Given this list of marker genes SOX7, MADCAM1, CYYR1, LINC01362, KANK3, CCM2L, NOTCH4, PLVAP, EMCN, KITLG, GALNT15, CLEC14A, TBXA2R, CPNE5, SELE, MEOX1, CLEC3B, PRND, TM4SF18, BCL6B, CD34, ESAM, ENSG00000248636, APLNR, A2M, ARHGEF15, EPAS1, PCDH12, TMEM233, NKX2-3, FLT1, here is a description of the gene set: studied in species Homo sapiens Marker genes curated from the annotated cluster as represented in the Descartes Human Gene Expression During Development database. The gene expression program underlying the specification of human cell types is of fundamental interest. The study authors generated human cell atlases of gene expression and chromatin accessibility in fetal tissues. For gene expression, the study authors applied three-level combinatorial indexing to >110 samples representing 15 organs, ultimately profiling ~4 million single cells. The study authors leveraged the literature and other atlases to identify and annotate hundreds of cell types and subtypes, both within and across tissues. Our analyses focused on organ-specific specializations of broadly distributed cell types (such as blood, endothelial, and epithelial), sites of fetal erythropoiesis (which notably included the adrenal gland), and integration with mouse developmental atlases (such as conserved specification of blood cells). These data represent a rich resource for the exploration of in vivo human gene expression in diverse tissues and cell types. from publication Cao J, O'Day DR, Pliner HA, Kingsley PD, Deng M, Daza RM, Zager MA, Aldinger KA, Blecher-Gonen R, Zhang F, Spielmann M, Palis J, Doherty D, Steemers FJ, Glass IA, Trapnell C, Shendure J (PMID 33184181) Human Gene Set: DESCARTES_FETAL_STOMACH_VASCULAR_ENDOTHELIAL_CELLS